The following is a description of a gene set: Human Gene Set: GOBP_NUCLEOBASE_CONTAINING_SMALL_MOLECULE_BIOSYNTHETIC_PROCESS The chemical reactions and pathways resulting in the formation of a nucleobase-containing small molecule: a nucleobase, a nucleoside, or a nucleotide. studied in species Homo sapiens, and this is the list of marker genes: DCTD, MTAP, ADA, TK1 (thymidine kinase 1), QNG1, DHFR2, PNP, APRT, PRTFDC1, DTYMK, ADK, UCKL1, MAPDA, PGM2, NT5E, DNPH1, TK2, ADA2, HPRT1